The following is a description of a gene set: Any process that modulates the frequency, rate or extent of nucleotide-excision repair. species: Homo sapiens Human Gene Set: GOBP_REGULATION_OF_NUCLEOTIDE_EXCISION_REPAIR, and this is the list of marker genes: ARID2, ACTL6B, BRD7, SMARCB1, SMARCC1, DPF2, BCL7C, KAT7, HMGB1, SMARCA4, CUL4A, PBRM1, DPF1, DPF3, ARID1B, PHF10, SMARCD2, SMARCD1, SMARCD3, SMARCE1, SMARCC2, SMARCA2, BCL7A, ACTL6A, ACTB, ARID1A, BCL7B, ERCC8, RAD52